The following is a description of a gene set: from publication Chen Y, Wang X (PMID 31504780) Mouse Gene Set: MIR_7076_3P species: Mus musculus Genes predicted to be targets of miRBase v22 microRNA mmu_miR_7076_3p in miRDB v6.0 with MirTarget v4 prediction scores > 80 (high confidence targets)., and this is the list of marker genes: Pot1a, Ttc3, Thra, Ctu2, Eml5, Gpr12, Gnpnat1, Sp3, Lcp1, Dnal1, Lrit1, Insm2, Rbms1, Sinhcaf (NCBI Gene Id 56306), Car5b, Rora, Nova2, Armcx3, Ccnjl (cyclin J-like), Ehd4, Vmn1r58, Tspan33, Ddost